Given this list of marker genes Gng5, Gng8, Gngt2, Gnb5, Mapk14, Gna13, P2ry1, Tbxa2r, Gng4, Gnai1, Gnb2, Gng3, Gngt1, Gna14, Gng11 (guanine nucleotide binding protein (G protein), gamma 11), Gng7, Gnat3, Gng10, Gnb3, here is a description of the gene set: species: Mus musculus Reactome Pathway: Signal amplification electronically inferred by orthology from the curated human pathway part of: Platelet activation, signaling and aggregation This event has been computationally inferred from an event that has been demonstrated in another species.<p>The inference is based on the homology mapping from PANTHER. Briefly, reactions for which all involved PhysicalEntities (in input, output and catalyst) have a mapped orthologue/paralogue (for complexes at least 75% of components must have a mapping) are inferred to the other species.